The following is a description of a gene set: species: Homo sapiens The chemical reactions and pathways involving compounds derived from amino acids, organic acids containing one or more amino substituents. Human Gene Set: GOBP_MODIFIED_AMINO_ACID_METABOLIC_PROCESS, and this is the list of marker genes: ABHD16A (NCBI Gene Id 7920), PANK2, EGLN2, PLOD2, GSTT2, SULT1A1, ATIC, NDP, IDH1, DUOXA2, SLC7A11, GCNT4, HPN, ALDH1L2, CROT, CKMT1A, PTDSS1 (NCBI Gene Id 9791), SLC1A1, GCLC (NCBI Gene Id 2729), GLO1, GSS (glutathione synthetase, NCBI Gene Id 2937), IYD, DIO1 (iodothyronine deiodinase 1), FTCD, SERINC2, SLC46A1, TG, ABHD16B, CHDH, SHMT2, TPO, FKRP, PM20D2, LPCAT3, LPCAT4, GSTP1, GGT1, GPX1, PAX8, GGT7, SLC22A4, PLA2G15, DUOX2, MTHFD2, TMLHE, GSTA3, GGT6, ALDH1L1, PLA2G10, P4HB, CRYM, SARDH, ALDH9A1, AASDHPPT, CTNS, GAMT, GATM, GSTT2B, SERINC5, PCYOX1L, DHFR2, OSBPL5, GSTM4, OSBPL8, GSTM2, GGT3P, MGST2, GGACT, FOLH1, CHAC1, ABHD12, GGTLC2, CRAT, HPGDS, G6PD, VNN2, SLC5A5, MTHFD1, GATA3, SULT1B1, GSTO2, BHMT2, GGT5, ETHE1, SLC16A10, PTDSS2, GSTZ1, MTHFS, MBOAT2, GSTA4, DPEP1, SHMT1 (NCBI Gene Id 9316), CGA, GGTLC3, ALDH7A1, PLA2G2F, PLSCR1, MTHFR, GGT2P, GSTO1, GNMT, BHMT, GSTM1, CPT1A, GSTA5, SULT1A4, BBOX1, GCH1, DUOX1, CHAC2, SLC16A2, GCLM, VNN1, SLC25A16, FOXE1, ACADL, AAAS, MTHFD2L, MTHFD1L, CKMT2, GGH, ALDH4A1, FOLR1, TYMS, SLC19A1, POR, FPGS, DUOXA1, ABHD12B, MTRR, CKB, SLC25A32, ASS1, CPT1C, ACADM, GSTA2, HAGH, MMACHC, MED1, GSTK1, MTR, ARL6IP5, CTSK, GSTT4, AGXT2, CKMT1B, DHFRP1, GLRX2, SLC1A2, CPT2, SULT2A1, GOT2, PLOD3, DIO2, CPQ, ICMT, GGTLC1, PCYOX1, NFE2L1, SLC25A42, HOGA1, CPT1B, SULT1A3, OSBPL10, CTSB, PLA1A, MBOAT1, SOD2, SLCO1C1, GSTA1, NAT8, PLA2G3 (NCBI Gene Id 50487), GSTT1 (glutathione S-transferase theta 1), SERINC1, DIO3, DMGDH, PANK4, SLC26A7, MFSD2A, PRODH, OPLAH, CKM, NFE2L2, SLC6A8, SOD1, GSTM3, DHFR, GSTM5, GSR, PARK7